Given this list of marker genes PINK1, SLC6A4, CNTNAP4, PNKD, FLOT1, PMCH, ARRB2, CHRNB2, PMCHL2, here is a description of the gene set: studied in species Homo sapiens Human Gene Set: GOBP_REGULATION_OF_SYNAPTIC_TRANSMISSION_DOPAMINERGIC Any process that modulates the frequency, rate or extent of dopaminergic synaptic transmission, the process of communication from a neuron to another neuron across a synapse using the neurotransmitter dopamine.